The following is a description of a gene set: G protein-coupled neurotransmitter receptor activity, occurring in the presynaptic membrane, involved in regulation of presynaptic membrane potential. studied in species Mus musculus Mouse Gene Set: GOMF_G_PROTEIN_COUPLED_NEUROTRANSMITTER_RECEPTOR_ACTIVITY_INVOLVED_IN_REGULATION_OF_PRESYNAPTIC_MEMBRANE_POTENTIAL, and this is the list of marker genes: Gabrb1 (gamma-aminobutyric acid type A receptor subunit beta 1), Gabbr1, Kctd12b, Kctd12, Kctd8, Kctd16